The following is a description of a gene set: Human Gene Set: GSE37605_C57BL6_VS_NOD_FOXP3_FUSION_GFP_TREG_DN species: Homo sapiens The aim of this study was to quantify the impact of chimeric Foxp3-GFP protein on the Treg cell transcriptional program. Genes down-regulated in Foxp3-Fusion-GFP T reg (FOXP3+): B6 versus NOD background. from publication Darce J, Rudra D, Li L, Nishio J, Cipolletta D, Rudensky AY, Mathis D, Benoist C (PMID 22579475), and this is the list of marker genes: APOLD1, INPPL1, OXNAD1, IER2, IPMK, DHRS3, GPR4, COPS8, TRAPPC1, CCR8, TMEM97, ATP6V1E1, NAGK, LANCL1, ARL4D, LAMP1, PLA2G15, TMCC3, GTF2H5, ABI2, TMEM199, DLL1, LRRN3, JDP2, RCAN1, DUSP5, ASPA, SNTB2 (syntrophin beta 2), CCL2, PLEKHO2, CD9, MS4A7, CCRL2, MMP13, RAB34, PLK2, PTPRM, IER3, VNN3P, SEC24D, ITM2A, NR4A1, BHLHE40, MRPL3, RAD54B, HAUS8, CEBPD, CTTN, EHD1, CSNK1E, C3AR1, IL1A, VPS37B, CIBAR1, GTF2B, PRDX6, AKAP12, TMEM120A, SPRY4, TBC1D8, ETFB, CASP7, AVEN, MT1A, SDC4, HNRNPLL, MRPL51 (NCBI Gene Id 51258), TANGO2, ZFAND5, MED28, CD14, MRPL48, FOSB, MGST1, RNF19B, VDAC1, MEIG1, ABHD12, JUN, TPM1, CP (ceruloplasmin), ZFP36, TNFAIP3, DUSP1, RAB43, SUV39H1, RPAP3, DOCK7, ID3, ABCD2, MAFF, TMEM106A, PLAUR, UBA2, PVR, BRD7, ELANE, SNX24, F11R, FAM98B, KDM6B, ACO2, LITAF, FADS2, PKD2, PSMC2, FOSL2, CLPTM1, NFKBIZ, KLF4, SCARB1, RPL3, CEBPB, LRP5, NUAK2, MGAT5, LACC1, MYB, CD300C, CH25H, ISY1, GDE1, GNAZ, MYO10, TM4SF1, SLC25A25, GAB2, SEMA4C, ADAMTS1, TRAPPC3, LONP2 (NCBI Gene Id 83752), CYYR1, PTGER4, SERPINE1, CCL24, TNFSF18, CDIN1, CCL3, KCNE4, PER1, ATF3, CBX7, ZFP36L1, ADAMTSL2, FADS1, NFIX, ITGB5 (integrin subunit beta 5), NFYC, EDN1, HSPA2, PPT2, GTPBP1, LILRB4, ANGPT2, RASL11B, PTGS2, CDCA5, ATOX1, PLXNB2, EEF1AKMT1, JUNB, MYC, SPRY2, SLC25A33, PDE4D, LRP4, DUSP6, MIR145, PLK3, BTG2, NFIL3, PLEKHM2, SPRY1, MAPKAPK3, H3-3B, MRPL18, NR4A3, EYA1, IL10, CDCA7, CD300E, CMKLR1, FOS, DENND1A, SNORD22, PSMD3, TNS2, TSEN15, IL6, SELENOS, ACKR3